Given this list of marker genes CYP3A4, CYP2C8, CYP2E1, CYP2D6, ALOX5, CYP2C9, EPHX2, CYP1A2, here is a description of the gene set: studied in species Homo sapiens Reactome Pathway: Biosynthesis of maresins part of: Biosynthesis of DHA-derived SPMs Maresins 1 and 2 (MaR1 and MaR2) are derived through the action of lipoxygenase 12 on the ω-3 fatty acid docosahexaenoic acid (DHA). MaRs are mainly produced by macrophages hence the derivation of the name from MAcrophage mediator RESolving INflammation. MaR1 exhibits potent anti-inflammatory, pro-resolving, analgesic and wound healing activities. Major cellular targets for the actions of MaR1 are vascular smooth muscle (VSM) cells and vascular endothelial cells. In these cells MaR1 attenuates the adhesion of monocytes to the endothelium induced by TNF-alpha. Maresin 1 also inhibits the production of reactive oxygen species by both VSM and endothelial cells. The major mechanism through which MaR1 exerts these effects is through down-regulation of the transcription factor, nuclear factor kappa-light-chain-enhancer of activated B cells (NFκB). MaR2 has been shown to reduce neutrophil infiltration and to enhance macrophage-mediated phagocytosis of dead and dying cells, a process termed efferocytosis. Two related structures, the maresin-like mediators (MaR-L1 and MaR-L2), are generated when the maresins produced by macrophages are released and acted upon by leukocytes and platelets. These, together with 14,21-dihydroxy-DHAs, rescue the reparative function of diabetes-impaired macrophages in diabetic wound healing.